Given this list of marker genes CLOCK, BMAL1, NCOA1, SERPINE1, NAMPT, BHLHE41, F7, CARM1, TBL1X, SMARCD3, CHD9, NOCT, BMAL2, CREBBP (NCBI Gene Id 1387), HELZ2, NCOA2 (NCBI Gene Id 10499), TBL1XR1, NCOA6, PPARA, BHLHE40, KLF15, NPAS2, AVP, RXRA, TGS1, MED1, here is a description of the gene set: BMAL1:CLOCK,NPAS2 activates circadian expression Human Gene Set: REACTOME_BMAL1_CLOCK_NPAS2_ACTIVATES_CIRCADIAN_EXPRESSION species: Homo sapiens